The following is a description of a gene set: Mouse Gene Set: CUI_MIGDC_IL36A_RESPONSE_UP from publication Cui A, Huang T, Li S, Ma A, Pérez JL, Sander C, Keskin DB, Wu CJ, Fraenkel E, Hacohen N (PMID 38057668) Cytokines mediate cell-cell communication in the immune system and represent important therapeutic targets. A myriad of studies have highlighted their central role in immune function, yet we lack a global view of the cellular responses of each immune cell type to each cytokine. To address this gap, the authors created the Immune Dictionary, a compendium of single-cell transcriptomic profiles of more than 17 immune cell types in response to each of 86 cytokines (>1,400 cytokine-cell type combinations) in mouse lymph nodes in vivo. A cytokine-centric view of the dictionary revealed that most cytokines induce highly cell-type-specific responses. For example, the inflammatory cytokine interleukin-1β induces distinct gene programmes in almost every cell type. A cell-type-centric view of the dictionary identified more than 66 cytokine-driven cellular polarization states across immune cell types, including previously uncharacterized states such as an interleukin-18-induced polyfunctional natural killer cell state. studied in species Mus musculus Genes positively differentially expressed in cell type: MigDC (migratory dendritic cell) upon treatment with cytokine: IL-36α in mouse lymph nodes in vivo., and this is the list of marker genes: Tpm4, Ppa1, Ifi204, Bcl2a1d, Atp6v0a1, Tcf4, Sp100, Pdcd1lg2, Got1, Syngr2, Ccl17 (C-C motif chemokine ligand 17), Fscn1, Snrpd3, Ahnak, Ascc3, Il10ra, Hnrnpa3, Il1b, Lima1, Dse, Calm1, Ywhag, Serpinb9, Oasl2, Ywhaz, Ktn1, Rap2b, Zup1, Nt5c3, Wasf2, Pik3r5, Socs1, Sema7a, Gbp2, Cxcl9, Stat4, Ly75, Ifitm2, Cebpb, Ifit1, Rnf213, Ptpn1, Arpc5, Sp110, Syncrip, Batf, Nr4a3, Igtp, Kif1a, Ranbp1, Pnp, Bcl2l11, Iqgap1, Vdr, Runx3, Calcrl (NCBI Gene Id 99263), Itga4, Ifi211, Shmt2, Ikzf1, Nckap1l, Csrp1, Tle3, Ifitm1, Glipr2, Ncl, Hnrnpc, Noct, Parp9, Fyn, Herc6, Ccnd2, Mmp25 (NCBI Gene Id 240047), Slfn5, Jak2 (Janus kinase 2), Macroh2a1 (NCBI Gene Id 26914), Eif5a, Ccl19, Tmbim6, Isg15, Cd274, Tap2, Acsl5, Casp4, Cycs, Trim30d, Filip1l, Abtb2, Cst3, Gbp5, Tmsb10, Hspd1, Zbp1, Samhd1, Irf9, Cers6, U2af1, Stat3, Ifi203, Actn1, Stat1, Nlrc5, AA467197, Stat2, Eif2ak2, Ifitm3, Larp1, Il1rn, Cox17, Clic4, Txnrd1, Trim30a, Fabp5, Snx10, Cytip, Cnn3, Bst2, Irgm1, Nampt, Ifi27l2a, Slfn2, Helz2, Tcf7, Cd82, Ehd1, Tspan13 (tetraspanin 13), Ifi35, Pdlim5, Srgn, Erh (NCBI Gene Id 19068), Cd86, Tpm3 (tropomyosin 3, gamma), Fbxw17, Cd200, Ldha, Bbx, Tuba1b, Cxcl10, Zyx (NCBI Gene Id 97340), Ube2l6, Xaf1 (XIAP associated factor 1), Ly6a, Hnrnpab, Irf7, Pkib, Dtx3l, Anxa2, Serpina3g, Ifi47, Pdia6, Atp11a, Parp14, Eif1a, Chmp4b, Srsf6, Mif, Rtp4